The following is a description of a gene set: Mouse Gene Set: chr9F2 studied in species Mus musculus, and this is the list of marker genes: Kif9, Ltf, Ccdc51, Slc26a6, Als2cl, Nckipsd (NCK interacting protein with SH3 domain), Spink8, Ccdc12, Celsr3, Mir6236, Ccdc71, Uqcrc1, Dhx30, 1700061E17Rik, Atrip, Elp6, Setd2, Mir711, Tma7, Prss44, Qrich1, Fam240a (family with sequence similarity 240 member A), Trex1, Gm23034, Plxnb1, Pfkfb4, Map4, Nbeal2, Gm24259, Mir425, Fbxw23, Fbxw28, Fbxw13, Col7a1, Tmie, Ucn2, Fbxw22, Fbxw21, Camp, Usp4, 4833445I07Rik, Gm23377, Shisa5, Fbxw25, Pth1r, Wdr6, Fbxw24, Fbxw14, Impdh2, Klhl18, Cspg5, Prkar2a, Klhdc8b, Prss45, 1700102P08Rik, Mir191, P4htm, Prss46, 3000002C10Rik, Fbxw19, Iho1, Rps2-ps11, Lrrc2, Lamb2, Ngp, Usp19, Mir8107 (NCBI Gene Id 102466885), Scap, Mir7089, Tmem89, Gm35715, Gm4644, Ndufaf3, Cripto, Cdc25a (NCBI Gene Id 52289), Arih2, Smarcc1, Slc25a20, Rtp3, Ip6k2, Fbxw20, Qars1, Fbxw15, Prss42, Fbxw18, Myl3, Gm7628, Gm25456, Prss50 (serine protease 50), Nme6, Rp31-ps19, Ccrl2, Dalrd3, BC048562, Ptpn23, Fbxw26, Gm26409, Fbxw16, Prss43, Fbxw27, Gpx1, 5830462I19Rik, Nradd, Gm4734, Gm35025